The following is a description of a gene set: from publication Billmann-Born S, Till A, Arlt A, Lipinski S, Sina C, Latiano A, Annese V, Häsler R, Kerick M, Manke T, Seegert D, Hanidu A, Schäfer H, van Heel D, Li J, Schreiber S, Rosenstiel P (PMID 21335489) species: Homo sapiens Human Gene Set: GSE22611_NOD2_TRANSD_VS_CTRL_TRANSD_HEK293_MDP_STIM_6H_UP Genes up-regulated in HEK293 cells at 6h after stimulation by muramyl dipeptide: over-expressing wildtype NOD2 versus control. NOD2 is an intracellular receptor for the bacterial cell wall component muramyl dipeptide (MDP) and variants of NOD2 are associated with chronic inflammatory diseases of barrier organs e.g. Crohn disease, asthma and atopic eczema. It is known that activation of NOD2 induces a variety of inflammatory and antibacterial factors. The exact transcriptomal signatures that define the cellular programs downstream of NOD2 activation and the influence of the Crohn-associated variant L1007fsinsC are yet to be defined. To describe the MDP-induced activation program, we analyzed the transcriptomal reactions of isogenic HEK293 cells expressing NOD2wt or NOD2L1007fsinsC to stimulation with MDP. Importantly, a clear loss-of-function could be observed in the cells carrying the Crohn-associated variant L1007fsinsC, while the NOD2wt cells showed differential regulation of growth factors, chemokines and several antagonists of NF-κB, e.g. TNFAIP3 (A20) and IER3., and this is the list of marker genes: GREB1L, ZNF154, AKAP12, PNMA1, TREH, MGAT2, THSD7A, ATP2A2, CTSK, ASPH (aspartate beta-hydroxylase), HSPB8, SEMA5A, PRORP, KDM5B, LILRA5, CROT, SAMM50, GK3, NFIB, PILRA, NEAT1, KRIT1, MAGEA5P, RPS27L, NRG1, SDC2, BYSL, ABCA12, PDE7B, SMOX, MAP3K20, EDC3, B4GALT2, MAP2K3, JMJD4, FXR1, GDF2, FUT2, CYP17A1, MPZL2, ARFIP1, PPIL6, NME5, RLIG1, F11R, CENPM, CLSTN3, PHTF2, XPO6, NUP93, NFKBIE, KIAA0930, GFAP, DUSP1, TRIM2, CAVIN1, BRD2, KIR2DS3, NINJ1 (NCBI Gene Id 4814), GATA2, TAS2R3, METTL1, CHRNA3, KSR1, GIN1, GAS1, GCGR, SLC17A4, ELK4, TCP10L3, NDUFB5, BET1, RPS18, PRUNE2, RANBP17, FBXW11, RHBDL1, SHCBP1L, UBE2D3, AP1G1, OR10H1, CCZ1B, FSHB (follicle stimulating hormone subunit beta), NONO (NCBI Gene Id 8253), ASCL3, KLRC3, CAB39L, TGFBR3, ALK, DGKQ, SEPTIN4 (septin 4), TNFRSF25, NPHP4, THAP4, FCRL2, UMPS, PTK2B, ITK, NUDCD3, KCNMB1, DCLK1, ZNF804A, MATCAP2, RPF1, VPS13B, SART1, TBX1, PTPRD, NEDD9, PAAF1, INA, LINC01711, AKR1B1, SSBP1, ERCC3, KRI1, MTMR11, ZNF248, WFDC8, RAB11FIP3, CFTR, CEACAM7, NAB1, PKNOX2, RARS1, IL2RG, HADHA, NELL1, LIG3, KLHL29, PVT1, NREP, EFNA3, JPH3, DNAH3, HSPA1A, HCG9, AGRP, ARPC5, SOX11, INHBC, SULF1, RSAD1 (radical S-adenosyl methionine domain containing 1), SYP, TSSK1B (testis specific serine kinase 1B), HEYL, NCOA2, TFE3, PLA2G4C, UCHL3, TLL2, REPS1 (RALBP1 associated Eps domain containing 1), VAT1, ZWILCH, PPP2R2B, CACNG5, NPVF, KLHL35, DECR1, NCAM2, SKA1, DYNC1I1, SNF8, VOPP1 (NCBI Gene Id 81552), HNRNPF, NLRP2, SBNO1, TAS2R9, CKAP2, SH3GLB1, IRAK4, ADAM8, ENSG00000274253, MARS1, BTN3A1, GSK3A, C3, APOB, PLEKHA4, TNFAIP2, NEUROG3, GAR1, RGS12, REC8, RS1, NUP62, PSMA5, MAP2, FSTL1, RRAS2, MPHOSPH10, ZNF556 (zinc finger protein 556), RAB14, RAP1B, PFKM, GALNT11, GPR17